Given this list of marker genes Rif1, Smchd1, Pnkp, Setmar, Shld1 (NCBI Gene Id 73747), Mad2l2, Cyren, Shld2, Shld3, Prkdc, Fh1, Kmt5b (NCBI Gene Id 225888), Kmt5c, Parp3, Kdm4d, Top2b, Wrap53, here is a description of the gene set: Any process that activates or increases the frequency, rate or extent of double-strand break repair via nonhomologous end joining. studied in species Mus musculus Mouse Gene Set: GOBP_POSITIVE_REGULATION_OF_DOUBLE_STRAND_BREAK_REPAIR_VIA_NONHOMOLOGOUS_END_JOINING